The following is a description of a gene set: species: Homo sapiens Any process that modulates the frequency, rate or extent of cell junction assembly. Human Gene Set: GOBP_REGULATION_OF_CELL_JUNCTION_ASSEMBLY, and this is the list of marker genes: MUSK, RAC3, ACTG1, CBLN1, ICAM5, RHOG, CRTAC1, MYO1C, TJP1 (NCBI Gene Id 7082), ARHGAP6, LRRC4B, UBE2M, WDPCP, NTRK3, RPS6, FLRT3, CNTNAP2, SLITRK3, RAPGEF2, MIR431, MMP14, EPHA7, CUX2, LRRTM3, GPRASP3, TLR2, PUM2, ARHGAP33, LZTS1, CBLN2, CAV1, FGFR1, NTRK1, SLC12A5, DKK1, PTPRS, HOPX (HOP homeobox, NCBI Gene Id 84525), PTPN1, RTN4R, GDF2, PTPN13, ADGRB1, LRRTM2, NAE1, NUMBL, CLSTN2, DSG3, F11R, TNF, PTPRA, EFNA5, NPHP1, MAP1B, EEF2K, CHD4, SYNDIG1, SNCA, CRB3, MIR142, IGSF11, LIN7A, CLDN5, FERMT2, MAP4K4, SLITRK6, SLC9A1, KDR, GPBAR1, BDNF, DUSP3, ELMO1, SEMA4C (NCBI Gene Id 54910), ACVRL1, CTNNB1, MYOC, DLC1, SRGAP2, CLSTN3, SLITRK4, PRKCA, SLITRK1, SNAI2, DAPK3, GREM1 (gremlin 1, DAN family BMP antagonist), NEDD8, SLK, ITGB1BP1, TEK, WNT3A, ADGRB2, CLSTN1, THY1, EPB41L5, EPHA2 (NCBI Gene Id 1969), LRTM2, DLG5, VCL, THBS2, PRICKLE1, ACE2, MDGA1, TSC1, NLGN3, APP, APOD, COLQ, WNT4 (NCBI Gene Id 54361), AGRN, ASIC1, PTK2, IL1B, AMIGO2, GNA13, PTPRJ, NEGR1, SIX4, EPHA3, PDLIM5, SDC4, OXT, SMAD3, IQSEC2, IL1RAP, WNT5A, CLDN1, CHRNB2, LRFN3, PTEN, PRKCH, GPC4, FLRT1, SRC, CAMSAP3, EPHB2, SENP1, LRP4, SRGAP2B, CLASP2, IL1RAPL2, NRP1, ROCK2, SIGMAR1, LRFN4, ST8SIA2, UBE3B, LIMS1, GHRL, RCC2, DOCK4, HRG, MIR105-1, MYCBP2, LIN7C, VEGFA, FZD1, SETD5, CC2D1A, POLDIP2, FLOT1, IL17A, CFL1, LRFN1, ARF6, NEURL1, CRMP1 (NCBI Gene Id 1400), SLITRK5, CORO1C, PEAK1, EPHB1, RAP1A, ARHGAP12, NLGN1, LRRN3, MACF1, SFRP1, LINGO2, VPS35, LATS1, DUSP22, RHOD, SEMA4A, NRXN2, NLGN2, TRIM47, IKBKB, THBS1, SRPX2, GPM6B, IL1RAPL1, NLGN4X, ACE, CARMIL3, AMIGO3, ASIC2, AMIGO1, SRGAP2C, SNAI1, PPM1F, S1PR2, AGT, PHLDB2, TPBG, CRIPT, VLDLR, DOCK1, NTRK2, CASKIN1, SEMA4D, NECTIN1, EIF4G1, EPHB3, FLRT2, ARHGEF15, PTPRD, LRRTM1, TBX5, RAP2A, CYFIP2, LRRN1, TLN1, LRFN5, FAM107A, NTNG2, LINGO4, MARK1, VSTM5 (V-set and transmembrane domain containing 5), RHOA, LIMCH1, STAU2, LIN7B (lin-7 homolog B, crumbs cell polarity complex component), ARMCX5-GPRASP2, ABI3, PDZD11, NRXN1, ZDHHC8, SLITRK2, NECTIN3, APLNR, LHFPL4, GRID2, WNT7A, DOCK10, NCKIPSD, FARP1, RAP1B, RAB17, LDB1 (LIM domain binding 1), PTK2B, CLASP1, S100A10, NPHP4, ROCK1, LRRC24, COL16A1, RAPGEF1, PPP1R9B, MEF2C, RTN4, NTN1, FZD5, OGT, ADGRB3, PRKACA, ROBO2, ADNP (activity dependent neuroprotector homeobox), RAC1, GHSR, HTR4 (5-hydroxytryptamine receptor 4), DMTN, IRX3, SIX1, ABL1, SLIT1